Given this list of marker genes MSANTD2, USP9X, SPIN1, LSM8, TMX1, SLCO3A1, ZNF99, PGAP1, KCNE4, CLDN22, RNF144A, MSI2, TENT4B, AAK1, TANC1, FIGN, NDFIP1, MARK1, MEOX2, NRIP1, PPP1R26, ZC3H6, KDM5B, SUCO, PDGFC, MSL2, ZNF529, TBX3, ZFAND5, MYO6, GXYLT1, TCF7L2, MMUT, PKP1, C4orf46, ITFG1 (integrin alpha FG-GAP repeat containing 1), AKAP6, STIM2, LAMB3, CRISPLD1, TRIO, TMEM132B, GABRB3, OTUD6B, FZD9, IVNS1ABP, DLL1, PLS3, PRDM5, SEC62 (SEC62 homolog, preprotein translocation factor), SMOC2, OMG, EYA1, USP3, CDC42EP3, PAK3, NAA15, SLC30A4, POM121, HEATR5A, AGXT2, ODF2L, GNG2, TAOK3, GPM6A, ATOSA, PCDH11Y, RBM27, MOCS2, MFN2, HK2, NECTIN1, OTUD4, ZNF503, ERCC6, ANO5, MAD2L1, MAP3K1, TET2 (tet methylcytosine dioxygenase 2), EDIL3, MIER3 (MIER family member 3), EPGN, PCM1, SEC24A, EGR2, SOX6, TSPYL1, FRY, TRAPPC11, GRAMD1C, PSMG4, LRP1B, TRIB2, RAP2B, TTN, UBFD1, ARL5A, MAP4K3, TMEM178B, RAP1GDS1, DMXL2 (NCBI Gene Id 23312), PRKG1, LEPR, SON (SON DNA and RNA binding protein), ADAMTS9, FGFBP3, DCAF8L1, MSANTD3-TMEFF1, TAF9B, CAPRIN2, NEK2, KBTBD2, PI15, SNAP25, SNX3, ZNF257, PDZD8, ZIC2, TRDN, MAPK8IP3, ZEB2, HACD4 (3-hydroxyacyl-CoA dehydratase 4), EDEM3, XKR4, JMJD1C, TFCP2L1, ZNF260, UEVLD, ZNF585A, SDCBP, MAN2A1, ERC2, POM121C, MAPK8, SNCAIP, UBE2E3, SCRIB, CACNA2D4, FOXN2, HOXA5, PDPK1, PITPNA, SLC17A6, PAPOLB, RUFY3, CCNL1, MAF, SEPTIN7, SUGP2, STXBP5L, PPP4R3A, FOXN3, IPO8, CEP44, FUT9 (NCBI Gene Id 10690), TENM3, UBE2D3, CXXC4, BCLAF1, TMEFF1, MBTPS2 (membrane bound transcription factor peptidase, site 2), BRD1, REEP3, MBD2, PPM1B, HOMER1, here is a description of the gene set: studied in species Homo sapiens Genes predicted to be targets of miRBase v22 microRNA hsa-miR-499a-3p in miRDB v6.0 with MirTarget v4 prediction scores > 80 (high confidence targets). from publication Chen Y, Wang X (PMID 31504780) Human Gene Set: MIR499A_3P